The following is a description of a gene set: from publication Ramirez K, Chandler KJ, Spaulding C, Zandi S, Sigvardsson M, Graves BJ, Kee BL (PMID 22608498) Expression profiling of Rag2-deficient Ets1++ and Rag2-deficient Ets1-- mature NK cells and WT bone marrow progenitors, WT T cells, and WT Pro B cells Human Gene Set: GSE37301_MULTIPOTENT_PROGENITOR_VS_LYMPHOID_PRIMED_MPP_UP Genes up-regulated in multipotent progenitors (MPP) versus lymphoid primed MPP cells. studied in species Homo sapiens, and this is the list of marker genes: POLR3E, OAS2, DENND6B, ZNF512B, NDST4, BCL9, RREB1, UBXN11, POLI, TTC14, USP18, SLC44A2, SP110, WDR74, RBM26, STN1, PUS3, HNRNPH3, CHD3, PLCB2, SLC41A3, HERC5, RGP1, CELF1, MRM3 (mitochondrial rRNA methyltransferase 3), RS1, NELFCD, SMURF2, ELK4, TMEM199, MUS81, ALG2, ARID3B, PRRC2C, NAXD, FUZ, PARP11, RPRD1A, CFB, PLEKHA1, RANBP6, TLR1, SLC5A9, SET, PPRC1, PTPRF, CDH24, PCDH1, SPNS1 (SPNS lysolipid transporter 1, lysophospholipid), POLR1E, ZBTB7B, POLRMT, CCL25, RAB33A, TPST1, AKAP8, TRMT10B, HSDL1, ZKSCAN3, RBM45, RGS10, PAN2, IPCEF1, LENG8, GRK6, GRAMD1A, EXOSC7, ACSS2, PIGY, TRUB1, AASDH, GSTT1, GPATCH11, SUGP2, ADCK5, ARHGEF1, RNF148, SEC61A2, ADCY10, GTF2A2, AMPD1, PTP4A3, MTRR, RASGRF2, MIA2, RETREG1, MTHFSD, MTR, TMEM86B, PSMD12, TNFAIP8L1, SPSB1, PNISR, NOL8, UNC50, TTC27, HERC3, PUS1, SDK1, SNAP47, CD96, CRIPTO, ZNRF1, LRRC42, DNAAF10, RNF167, OASL, DCAF6, SOX10, GPR146, NDOR1, PTPN6, AASDHPPT, SLFN5, IFRD2, PLEKHG2, TMEM19, SYNM, VAV1, RPP38, CHST15, TFEC, GGPS1, BPHL, FAM184B, SLC16A10, SLC44A1, IKBKE, TARS1, RGL2, ZFP1, NISCH, ZFC3H1, METTL2B, CAGE1, DDX17, CISD1, HOGA1, LUC7L3, TMEM80, EME2, ICE2 (NCBI Gene Id 79664), POFUT1, DDX60, MPP1, UTP15, DIDO1, RARS2 (arginyl-tRNA synthetase 2, mitochondrial), DCUN1D1, PARP8, FAM3C, SRSF1, PPM1L, NLK, AMPD3, TREML2, PBX2, N6AMT1